Given this list of marker genes CRTC1, PARP15, TBKBP1, SLC8A2, CBX6, UBN2, DNAJB5, CORIN, JPT2, STAT6, GARS1 (NCBI Gene Id 7972), DAGLA (diacylglycerol lipase alpha), FKBP14, ETV5, MFSD4B, ZSWIM4, GNA14, SPRR1B (NCBI Gene Id 6699), CPNE3, CAST, IGF2, NHSL1, CDK13, DHRS13, DBT, CIC, FXR2, CCDC186, FSBP, PIP5K1A, SEMA4G, TMEM169, STX1B, here is a description of the gene set: Human Gene Set: MIR6835_5P species: Homo sapiens from publication Chen Y, Wang X (PMID 31504780) Genes predicted to be targets of miRBase v22 microRNA hsa-miR-6835-5p in miRDB v6.0 with MirTarget v4 prediction scores > 80 (high confidence targets).